Given this list of marker genes SERPINA1, PCK1, COX16, UGT1A1, PEX1, COG4, SLC7A7, MEFV, MARS1, CPT1A, HADHB, MRM2, GBA1, MMEL1, CTC1, POLG, IRF5, PIGA, CYP7B1, POT1, BMP6, MT-ND1, F13B, PTPN22, GPR35, MT-ND5, OTC, HFE, TCF4, DGUOK, EIF2AK3, FOCAD, IKZF1, PEX14, TFAM, ASL, SH2D1A, IFT172, MPI, CC2D2A, MT-TT (NCBI Gene Id 4576), ENG, F5, AMACR, IL21R, ACVRL1, ACTG2, APOA1, DKC1, ZNFX1, DCDC2, XIAP, POU2AF1, PEX13, PEX3, MT-ND3, NDUFS4, RINT1, SPIB, BTNL2, HADH, SCARB2, MED12, ASAH1, NPC1, PEX16, JAK2, TERC, SC5D, MT-ND4, PARN, BRAF, LIPA, POLG2, DLD, H4C3, MT-ND2, PORCN, PEX19, NHP2, PEX2, NPM1, WRAP53, SCYL1, BAAT, RYR1, ACAD9 (acyl-CoA dehydrogenase family member 9), IFT122, TNFSF15, HLA-DRB1, SLC25A20, SP110, IL12RB1 (NCBI Gene Id 3594), COQ2, CLDN1, ALMS1, IL12A, P4HA2, ALDOB, IL18BP, SLC2A2, ITCH, CYC1, NRAS, PCK2, CPT2, PEX5, HLA-B, LARS1, TNPO3, TRMU, MRPS7, GALT, UBR1, INPP5E, CCDC115, SMAD4, CALR, MT-TL1, NR1H4, HSD3B7, RBM10, SKIC3, USB1, CACNA1S, RPGRIP1L, HADHA, TJP2, MPV17, STX5, EPM2A, FECH, PEX10, MT-TK, SMPD1, F13A1 (NCBI Gene Id 2162), PEX6, OSTM1, MT-ND6, SLC25A15, TMEM67, AKR1D1, KRT18, MT-ATP6, PEX11B, ATP7B, TERT, FH, MAP2K1, JAG1, ABCD3, PEX12, NBAS, RTEL1, SEMA4D, DEF6, GDF2, MT-TV, TYMS, NHLRC1, MT-TW, PEX26, FAH, GBE1, ATRX (ATRX chromatin remodeler), NOP10, TINF2, GFM1, IARS1, MST1, here is a description of the gene set: Human Gene Set: HP_HEPATIC_FAILURE Hepatic failure studied in species Homo sapiens